Given this list of marker genes PSMD13, PSMC2 (NCBI Gene Id 5701), PSMB6, SEM1, DERL1, UBC, ABCD1, PSMA3, RNF185, PSMD12, ABCB4, ABCA3, PSMB1, PSMD3, ABCC8, ABCG8, PSMD14, ABCD4, PSMC3, PSMC5, PSMB3, KCNJ11, PSMA6, ERLEC1, ABCC6, PSMD1, APOA1, LMBRD1, ABCA1 (NCBI Gene Id 8371), PSMD2, PSMD8, PSMB5, PSMA7, ERLIN2, DERL2 (NCBI Gene Id 95558), SEL1L, PSMA4, ERLIN1, UBB, PSMC1, PSMB2, PSMD11, PSMA5, ABCG5, ABCB11, UBA52, PSMB4, ABCB6, RNF5, ABCC2, PSMB7, DERL3, PSMA1, PSMD6, PSMC6, RPS27A, PSMA2, OS9, PSMD7, ABCA12, CFTR, ABCC9, PSMC4, ADRM1, VCP, here is a description of the gene set: studied in species Homo sapiens Human Gene Set: REACTOME_ABC_TRANSPORTER_DISORDERS ABC transporter disorders